The following is a description of a gene set: Mouse Gene Set: CUI_MIGDC_IL13_RESPONSE_DN Genes negatively differentially expressed in cell type: MigDC (migratory dendritic cell) upon treatment with cytokine: IL-13 in mouse lymph nodes in vivo. species: Mus musculus from publication Cui A, Huang T, Li S, Ma A, Pérez JL, Sander C, Keskin DB, Wu CJ, Fraenkel E, Hacohen N (PMID 38057668) Cytokines mediate cell-cell communication in the immune system and represent important therapeutic targets. A myriad of studies have highlighted their central role in immune function, yet we lack a global view of the cellular responses of each immune cell type to each cytokine. To address this gap, the authors created the Immune Dictionary, a compendium of single-cell transcriptomic profiles of more than 17 immune cell types in response to each of 86 cytokines (>1,400 cytokine-cell type combinations) in mouse lymph nodes in vivo. A cytokine-centric view of the dictionary revealed that most cytokines induce highly cell-type-specific responses. For example, the inflammatory cytokine interleukin-1β induces distinct gene programmes in almost every cell type. A cell-type-centric view of the dictionary identified more than 66 cytokine-driven cellular polarization states across immune cell types, including previously uncharacterized states such as an interleukin-18-induced polyfunctional natural killer cell state., and this is the list of marker genes: Hspa1a, Fos, Dusp1, Jun, Mt1, Hspa1b (NCBI Gene Id 15511), Tmem158, Tspan3, Fosb